The following is a description of a gene set: Genes highly expressed in the neonatal hippocampus (clusters 4 and 8). from publication Mody M, Cao Y, Cui Z, Tay KY, Shyong A, Shimizu E, Pham K, Schultz P, Welsh D, Tsien JZ (PMID 11438693) studied in species Mus musculus We have analyzed the developmental molecular programs of the mouse hippocampus, a cortical structure critical for learning and memory, by means of large-scale DNA microarray techniques. Of genes and expressed sequence tags examined, 1,926 showed dynamic changes during hippocampal development from embryonic day 16 to postnatal day 30. Gene-cluster analysis was used to group these genes into 16 distinct clusters with striking patterns that appear to correlate with major developmental hallmarks and cellular events. These include genes involved in neuronal proliferation, differentiation, and synapse formation. A complete list of the transcriptional changes has been compiled into a comprehensive gene profile database (http://BrainGenomics.Princeton.edu), which should prove valuable in advancing our understanding of the molecular and genetic programs underlying both the development and the functions of the mammalian brain. Mouse Gene Set: MODY_HIPPOCAMPUS_NEONATAL, and this is the list of marker genes: Lpl, Tubb2b, Chl1, Tars1, Mmp14 (NCBI Gene Id 17387), Fasn, Fdps, Cdh2, Cct5, Myef2, Usp22, Cct4, St8sia2, Cct8, Tuba1b, Vars1, Cct7, Tubb5, Sqle, Tbca, Col4a1, Tnc, Fn1 (fibronectin 1), L1cam, Actg1, Nrp1, Ncam1, Tuba1a, Fabp5, Tuba3a, Actg2, Ube2e3, Fabp7